The following is a description of a gene set: Any process that modulates the frequency, rate or extent of protein localization to centrosome. species: Homo sapiens Human Gene Set: GOBP_REGULATION_OF_PROTEIN_LOCALIZATION_TO_CENTROSOME, and this is the list of marker genes: MARK4, RAB11FIP3, RAB11A, NSFL1C, NUP62, PARD6A, APC (APC regulator of WNT signaling pathway), CEP72, CEP250, GSK3B, UBXN2B, BICD1